The following is a description of a gene set: Human Gene Set: REACTOME_GAP_JUNCTION_TRAFFICKING_AND_REGULATION Gap junction trafficking and regulation species: Homo sapiens, and this is the list of marker genes: ACTG1, GJB4, GJB6, GJA9, GJB7, TUBAL3, CLTB, GJA1, GJC2, DAB2, DNM1, GJB1, TUBB8, GJD3, TUBB8B, GJA3 (gap junction protein alpha 3), TUBA1A, TUBB6, GJA10, TUBB2B, TUBA1C, DNM2, GJA5, GJD2, GJB5, TUBB2A, SRC, GJA8, GJD4, GJA4, TUBA4A, TUBA3C, TUBB1, TJP1, TUBA3E, TUBB4A, MYO6, TUBA3D, TUBA8, GJC1, CLTCL1, CLTC, AP2M1, ACTB (actin beta), GJB3, TUBB4B, TUBA4B, CLTA, TUBB3, TUBA1B, GJB2